The following is a description of a gene set: Human Gene Set: HP_ABNORMAL_OVARIAN_PHYSIOLOGY studied in species Homo sapiens Abnormal ovarian physiology Any anomaly of ovarian function., and this is the list of marker genes: B4GALNT1, AIRE, EIF2B1 (NCBI Gene Id 1967), NUP107, FGF17, NHLH2, CHD7, CHP1, SPATA22, TWNK, NPHP4, STAG3, WDR11, AIP, TRAF3IP1, GNRH1, BNC1, FIGLA, FASLG, FMR1, FAS, MSH4, NBN, NR5A1, FSHB, XRCC2, POLG, BMP15, HFM1, GNRHR, KISS1, MRPS22, KASH5, HSF2BP, PROKR2, POF1B, RCBTB1, ZSWIM7, SPIDR, ZMPSTE24, THOC6, KISS1R, MEIOB, MCM8, TACR3, ATM, DIAPH2, POLG2, LMNA, ERCC4, NSMF (NMDA receptor synaptonuclear signaling and neuronal migration factor, NCBI Gene Id 349336), IQCB1, POLR3H, DCAF17, MEN1, GALK1, TTI2, FSHR, CEP290, GALT, INVS, SYCP2L, ANAPC7, FOXL2, PSMC3IP, TAC3, CEP164, PMM2, BLM, FGF8, NOBOX, HS6ST1, BMP4, SPRY4, SDCCAG8, PROK2, RIN2, WDR19, C14orf39, PRLR, FGFR1, ERAL1, CASP10, AGK, NPHP3, NPHP1, EIF2B2, AARS2, MCM3AP, DUSP6, CDH23, LARS2, GGPS1, ANAPC1